The following is a description of a gene set: Genes whose expression is coregulated with that of FGF3 in hematopoietic stem cells (HSC). Human Gene Set: BYSTRYKH_HEMATOPOIESIS_STEM_CELL_FGF3 from publication Bystrykh L, Weersing E, Dontje B, Sutton S, Pletcher MT, Wiltshire T, Su AI, Vellenga E, Wang J, Manly KF, Lu L, Chesler EJ, Alberts R, Jansen RC, Williams RW, Cooke MP, de Haan G (PMID 15711547) We combined large-scale mRNA expression analysis and gene mapping to identify genes and loci that control hematopoietic stem cell (HSC) function. We measured mRNA expression levels in purified HSCs isolated from a panel of densely genotyped recombinant inbred mouse strains. We mapped quantitative trait loci (QTLs) associated with variation in expression of thousands of transcripts. By comparing the physical transcript position with the location of the controlling QTL, we identified polymorphic cis-acting stem cell genes. We also identified multiple trans-acting control loci that modify expression of large numbers of genes. These groups of coregulated transcripts identify pathways that specify variation in stem cells. We illustrate this concept with the identification of candidate genes involved with HSC turnover. We compared expression QTLs in HSCs and brain from the same mice and identified both shared and tissue-specific QTLs. Our data are accessible through WebQTL, a web-based interface that allows custom genetic linkage analysis and identification of coregulated transcripts. species: Mus musculus, and this is the list of marker genes: BMP8A, BMP8B, POU5F1, EFNB1, EFNB3, MAP2K6, SH3RF1, PKNOX1